Given this list of marker genes BIRC7, GRIK5, FDPS, ARRDC4, PXT1, JPH4, AMIGO1, DHX58, GSTCD, ADRB3, IQGAP3, CFAP418, GNA11, LOXL3 (lysyl oxidase like 3), KCNK4, VANGL2, PTPRG, HHIP, CCDC3, SMTN, TNFRSF12A, FGF7, AGMAT, FAM222A, KIAA1958, MAMLD1, CELA2A (chymotrypsin like elastase 2A), FEZF1, UBE2E2, EIF2AK1, STARD10, DCAF10, IL1R1, METTL27, MRO, ARHGAP19, FAM110C, MED13L, MESP2, LRRC56, SLC26A3, EPN3, LBX1, SLC30A10, TMEM132C, KANSL1L, TNP1, PML, NFXL1, TFCP2, DNAJC10, GPIHBP1, WIPI1, PGM5, NRAP, STK11, KIF27, CDK5R2, METTL13, SPINK4, SNAP91, C11orf24, CITED4, DHX32, BBS10, B3GNT7, PLA1A, GARIN5A, CDH22, ALDH1L1, FBLIM1, ACOX2, ABCA3, CNTLN, MFAP4, RNF123, FIRRM, COL6A3, CNIH2, SYNPO2, NUP85, THBS4, SPACA4, ADGRB1, PENK, C1QL2, MROH2B, WIPI2, GPR87, IGFBPL1, INS, SESTD1, GUCD1, SLC30A9, RNASE6, CST9L, WDR76, MARCHF3, MARCHF10, SERTAD3, SLC16A12, TRIB1, FBLN2, EPHX3, NPTX1, ACKR4, PLPPR3, FAM169A, CELF6, GFRA1, FSCN1, RNF141, KCTD20, KRTAP4-11, ICAM5, STOML2, NR2F1, PCNT, COL4A1 (collagen type IV alpha 1 chain), SEMA4G, TWIST2, BTG3, FXYD2, GULP1, KLF17, IL36A, KCND2 (potassium voltage-gated channel subfamily D member 2), SCYL2, DUOX1, MIIP, PHACTR4, SLC16A11, WDR62, PXMP2, DYRK1A (dual specificity tyrosine phosphorylation regulated kinase 1A), EPCIP, SLK, MEMO1, TIAM1, PMFBP1, SPNS3, GHRHR, PRL, NID1, RGS6, CORO2B, MYEF2, KIF23, PPM1D, GAS1, HAND1, USP6NL, WDR55, TEAD4, MUC4, TSSK3, LGI3, TRIM46, EXT1, SHC1, SLC7A9, SPATA17, UROC1, NPY, MDM1, ANXA8, DOC2B, RAD54B, STX2, DHFR, YAP1 (Yes1 associated transcriptional regulator), HS6ST2, TBC1D21, PRICKLE2, MPP3, NRF1, BOK, HNF1B, GSDMC, DCAF8, SMAD6, DNM1, MMRN2, GRIA2, MAVS, FHL5, DIXDC1, TRIM59, FBXO16, KIF20B, ABRAXAS1, NDC80, FLRT2, RNF19A, VCAN, VSNL1, FAM170B, TMEM92, GAL3ST4, FBXO34, here is a description of the gene set: from publication Konuma T, Nakamura S, Miyagi S, Negishi M, Chiba T, Oguro H, Yuan J, Mochizuki-Kashio M, Ichikawa H, Miyoshi H, Vidal M, Iwama A (PMID 21540074) Genes down-regulated in comparison of NKT cells versus erythroblasts. Each fraction of mouse hematopoietic cells was purified by cell sorting from bone marrow of 8-week-old C57BL/6 mice, and its gene expression was analyzed. species: Homo sapiens Human Gene Set: GSE27786_NKTCELL_VS_ERYTHROBLAST_DN